The following is a description of a gene set: studied in species Homo sapiens SARS-CoV-2 targets host intracellular signalling and regulatory pathways Human Gene Set: REACTOME_SARS_COV_2_TARGETS_HOST_INTRACELLULAR_SIGNALLING_AND_REGULATORY_PATHWAYS, and this is the list of marker genes: YWHAQ, YWHAB, AKT3, SFN, CAV1, YWHAZ (tyrosine 3-monooxygenase/tryptophan 5-monooxygenase activation protein zeta), YWHAE, YWHAH, AKT1 (AKT serine/threonine kinase 1), YWHAG, PDPK1, AKT2